Given this list of marker genes Pax5, Cbfb, here is a description of the gene set: species: Mus musculus electronically inferred by orthology from the curated human pathway This event has been computationally inferred from an event that has been demonstrated in another species.<p>The inference is based on the homology mapping from PANTHER. Briefly, reactions for which all involved PhysicalEntities (in input, output and catalyst) have a mapped orthologue/paralogue (for complexes at least 75% of components must have a mapping) are inferred to the other species. part of: Transcriptional regulation by RUNX1 Reactome Pathway: RUNX1 regulates transcription of genes involved in BCR signaling